Given this list of marker genes GSTM1, CA2, CA11, MAZ, CA6, SMS, GSTM2, TTF2, CA14, here is a description of the gene set: species: Homo sapiens This study aimed to identify gene expression markers shared between both influenza hemagglutination inhibition (HAI) and virus-neutralization antibody (VNA) responses. We enrolled 158 older subjects who received the 2010-2011 trivalent inactivated influenza vaccine. Influenza-specific HAI and VNA titers and mRNA-sequencing were performed using blood samples obtained at Days 0, 3 and 28 post vaccination. For antibody response at Day 28 versus Day 0, several gene sets were identified as significant in predictive models for HAI (n=7) and VNA (n=35) responses. Five gene sets (comprising the genes MAZ, TTF, GSTM, RABGGTA, SMS, CA, IFNG and DOPEY) were in common for both HAI and VNA. For response at Day 28 versus Day 3, many gene sets were identified in predictive models for HAI (n=13) and VNA (n=41). Ten gene sets (comprising biologically related genes, such as MAN1B1, POLL, CEBPG, FOXP3, IL12A, TLR3, TLR7 and others) were shared between HAI and VNA. These identified gene sets demonstrated a high degree of network interactions and likelihood for functional relationships. Influenza-specific HAI and VNA responses demonstrated a remarkable degree of similarity. Although unique gene set signatures were identified for each humoral outcome, several gene sets were determined to be in common with both HAI and VNA response to influenza vaccine. Genes down-regulated in peripheral blood mononuclear cell 28d vs 0d in adults (50-74) (in common with both HAI and VNA) after exposure to Fluarix, time point 28D, administered i.m.. Comment: Common Genesets with genes entering regression models for HAI and VNA Responses with the log2 Day 28 vs Day 0 fold-change in gene expression as the explanatory variables. from publication Ovsyannikova IG, Salk HM, Kennedy RB, Haralambieva IH, Zimmermann MT, Grill DE, Oberg AL, Poland GA (PMID 27534615) Human Gene Set: OVSYANNIKOVA_PBMC_FLUARIX_AGE_50_74YO_COMMON_WITH_BOTH_HAI_AND_VNA_28DY_VS_0DY_USED_IN_HAI_AND_VNA_RESPONSE_MODELS_DN